The following is a description of a gene set: Reactome Pathway: Defective EXT2 causes exostoses 2 Heparan sulfate (HS) is involved in regulating various body functions during development, homeostasis and pathology including blood clotting, angiogenesis and metastasis of cancer cells. Exostosin 1 and 2 (EXT1 and 2) glycosyltransferases are required to form HS. They are able to transfer N-acetylglucosamine (GlcNAc) and glucuronate (GlcA) to HS during its synthesis. The functional form of these enzymes appears to be a complex of the two located on the Golgi membrane. Defects in either EXT1 or EXT2 can cause hereditary multiple exostoses 1 and 2 respectively (MIM:133700 and MIM:133701), autosomal dominant disorders characterised by multiple projections of bone capped by cartilage resulting in deformed legs, forearms and hands. species: Homo sapiens part of: Diseases associated with glycosaminoglycan metabolism, and this is the list of marker genes: GPC4, GPC6, SDC1, SDC2, GPC3, AGRN, EXT2, SDC3, HSPG2, GPC2, EXT1, GPC5, GPC1, SDC4